Given this list of marker genes RALYL, LINC00668, CLUL1, ARHGAP22, PSMA7, NDUFB3, PCBP3, ADM2, GPI, CAPN8, SUSD1, GAS6, LSAMP, CDH18, SEZ6L2, TMCO3, LINC00581, PIDD1, NCDN, NHLH2 (NCBI Gene Id 90888), LINGO2, THAP4, ISOC1, KIAA0930, NAA38, HSPB2, TMEM151A, DEFB1, CPEB1, PKP2, HK1, ACHE, ATP13A2, TMEM238L, MDH1, TUBA4A, ADARB1, MAST4, CDK14, UQCR10, INSIG1 (NCBI Gene Id 3638), DDAH1, EPPK1, MICOS10, ADAMTS2, VAT1, ST6GALNAC2, PPARGC1A, G6PC3, CKMT1A, OAF, ATP1A3, GOT1, GPR153 (NCBI Gene Id 387509), SNCB, STMN3, FAIM2, FBLN1 (NCBI Gene Id 2192), AHNAK, ATP6V1A, EPHA8, SELENOW, PLSCR4, PPL, BAIAP2, KIF5C, NTRK1, ST6GALNAC5, PARD3 (NCBI Gene Id 56288), SLC2A6, NDUFS8, KCNIP4, INSM2, ARHGDIG, PCSK1N, PKP1, SPINK5, LHX5-AS1, PTPRN2, PCOLCE2, ANXA6, PGRMC2, FBLN2, C1orf53, SV2B, MXRA5, GDF5, HSPA12A, HINT1, IGFBP5, GNG3, THSD7A, POLR2L, CLCF1, ATP6V0C, DUBR, GUK1, TMEM163, NDUFB9, NPTXR, CBLN1, TPBG, SNAP25 (NCBI Gene Id 6616), VAT1L (vesicle amine transport 1 like), KRT16P3, EMX2OS, PRAF2, OPCML, ADCYAP1, LHX1, BCAR3, DUSP23, C1QTNF3, PRKAR1A, ISOC2, FKBP2, EFNA3, CMC2, CNGA3, CCDC13, CASZ1, MAP4, PGAM1, PRDX5, LYNX1, SLC22A15, HYAL3, RAB37, GABRG1, SNCA, COL18A1, BEX2, GCHFR, ZNF488, NQO1, ANTKMT, HHATL, NACC2 (NCBI Gene Id 138151), ME1, TMEM255B, NEFH, CACNA2D3, COX6C, DEGS1, NCOA7, KCNK4, CLU, COPS7A, COX6A1, TMEM59L, WFIKKN2, TMEM50B, GAP43, PCP4, MFAP2, ACYP2, PEG3, MAP1A, ATP6V1E1, ATP5MK, FANK1, LTB4R, NDUFB8, OTOS, IGSF9, NDUFB6, TSPAN33, EMX2, ZNF503-AS2, CDKN1A, PCP4L1, PTPRN, CRABP2 (NCBI Gene Id 1382), HSD17B12, NSG1, APLP2, LINC00871, KIAA1217, VEGFB, ZIC2, DIABLO, TMEM229A, NDRG4, B4GAT1, PRPH, RAB6B, SOD1, CYB5R3, TCTA, FAM167A, PPP2R1A, FRMPD1, CTNNB1, CLSTN1, TNFRSF11A, CYSTM1, GSTT1, NDUFB7, MMP15, TMEM45A (NCBI Gene Id 55076), HIGD1A, CLEC2L, SCARA3, TRH, B3GNT4, ACKR1, RHBDD2, SCGB1D2, AGPAT1 (NCBI Gene Id 84827), RAB11FIP2, FCER1A, ATP5IF1, LINC01990, CKMT1B, SYNGR3, FAM162A, HSPB8, ADRA2C, RCAN2, WNT4, PHLDA3, ELAPOR1, EBP, DHRS11, CD164L2, MAOA, TXN, TIMM17A, NELL1, NDUFAB1, RELN, COX4I1, PLD3, ADAM12, TM7SF2, RTBDN, LAPTM4A, F12, SLC25A5, DIRAS2, PDE4B, SPINT2, C1orf122, SEZ6L, KLHL13, MRPL41, PGF, ALDOA, FST, PKM, SDSL (NCBI Gene Id 113675), CHGB, UBE2E2, MXRA7, CEND1, HAGH, INAFM1, ACSL4, NIPAL3, TP73, CPE, HS6ST2, TSPO, COX7C, ATP5ME, ROGDI, SEC61A2 (SEC61 translocon subunit alpha 2), UROS, COX14, COX5A, EPDR1, ITGA11, ATP6V1H, EGFLAM, GADD45A, ATP6V0E2, GPR6, CYP26A1, CYP4X1, ACOT7, NOL3, CRYAB, PTPRU, PYGB, TSTD1, COL6A1, SPRYD3, RTL8C, RAB3A, MSMO1, ST6GALNAC3, NDUFA8, CCDC88C, MFSD4A-AS1, NPB, QPCT, BNIP3, NEFL, ATP5F1B, TANK, RHEB, ENO2, GNAL, SUSD4 (sushi domain containing 4), DMRTA2, NDNF, HMGCS1, CALY, ECEL1, MECR, FAM118A, GNG12, UQCR11, MAB21L1, NDUFA11, PFKP, SLC27A6, MRAP2, FBXO2, VSTM4, TSPAN9 (NCBI Gene Id 83441), ATP5F1E, ENTPD3, FKBP9, AMIGO2, DHCR7, CPNE9, CCDC85A, SNRNP25, LGALS1, ATP5F1A, RCAN1, ACLY, NDUFA9, PLOD2, PIN1, NEFM, GRM2, PRKAG2-AS1, MAP1LC3A, CALM3, PCMT1, PLPP2 (NCBI Gene Id 8612, phospholipid phosphatase 2), MARCHF1, COX8A, ANKRD29, DNAJC12, GHRH, STS, RBMS1, NUPR1, SLC35F2, KLC1, GSG1L, TSPAN3, RGMA, ERICH5, GALR2, CRACR2B, BCAP31, NRN1, PLCL1, REEP2, CHST2, GFRA2, SCGB1D1, WRAP73, ANGPT1, C7, S100A16, LY6E, FSTL5, DEGS2, RSPO3, DMRT3, ATP6V1G2, MGST3, STK32C, CYB561, LHFPL6, GGH, AGPAT2, TPRG1L, ATF5, FDPS, PRKAG2, GSTP1, MARCKSL1, TUBB4B, SLC18A3, TMEM130, NDUFA12, NALF1, CAMK2D, CABP7, COPS8, CALB2 (NCBI Gene Id 794), TMEM47, DNER, TOLLIP, NCS1, L1CAM, CYCS, KRT222, IZUMO4, LINC00316, ATP6V0B, STPG1, TXNL4A, STX1A, TUSC3, SERTM1, STK32A, SCOC, LY6H, ZNF503, GPR37, LINC01133, ZIC5, PLD1, WIF1, AIM2, RASSF6, MYH14, CA2, C11orf87, COX5B, COX7B, GARIN5A, FSTL4, HTR5A, AKAP1, TAGLN2, LHX3, PLCB4, SMIM29, HPCAL1, CPM, CAPN1, EBF3, NDUFA13, NIPSNAP3A, SHISA2, NUPR2 (NCBI Gene Id 442546), IRF6 (interferon regulatory factor 6), CNTNAP1, MAP7D2, CNTNAP2, SCN4B, HLA-A, CBLN4, CDH1, MFSD4A, TPI1, ITM2C, UBASH3B, ITGA4, ABLIM1, ATP5PD, DDT, NAP1L5, CD47, NDUFA1, COX7A1, ATP5MC3, RSPO2, FNDC5, LSM4, PERP, PTCHD1-AS, MAP1LC3B, SLC25A4, TMEM14A, CDH4, ATP5F1C, OLFM1, CDIP1, THSD7B, SYP, CYP3A5, PRDX2, ABCA17P, SCG2 (secretogranin II), ATP5MC1, CYB5A, SLC41A3, SAA1, CXXC5, BRINP3, LDHB, CLSTN2, CYGB, ATP6AP1, PCSK1, GHITM, SLC17A6 (NCBI Gene Id 57084), SCG5, AGTR1, GREM2 (NCBI Gene Id 64388), SPOCK2, here is a description of the gene set: from publication Fan X, Dong J, Zhong S, Wei Y, Wu Q, Yan L, Yong J, Sun L, Wang X, Zhao Y, Wang W, Yan J, Wang X, Qiao J, Tang F (PMID 29867213) species: Homo sapiens Human Gene Set: FAN_EMBRYONIC_CTX_BIG_GROUPS_CAJAL_RETZIUS